Given this list of marker genes ALOX5, RALGPS2, TRMT112, TACSTD2, PLOD1, PDSS2, PTP4A1, F2RL1, B3GNTL1, RNF141, RFC2, CXCR1, ADGRE2, TBL1X, POLB, SORL1, RAB11FIP1, G6PD, TACC3, RPS6KA5, APOBEC3A, NDST1, NUDT15, RAB3A, PECAM1, OSBPL9, GRAMD1C, KAT6A, ZNF407, TNRC6B, BMX, STK17A, FYB1, MERTK, HAL, NDUFB6, USP6NL, SLC25A37, SIPA1, TGM5, WRAP73, PIGF (phosphatidylinositol glycan anchor biosynthesis class F), RBPJ, CORO1A, ABCC5, TRANK1, TCAP, FRAT2, RXRA, IFRD1, MT4, MNDA, RAF1, HMGCR, ELOVL5, ARHGDIB, SMCHD1, CEACAM21, BIN2, ATXN7, P2RY13, GAPDH, MPPE1, INKA2, TUBA4A, USP3, FOS, CAMK2G, CDA, AADAC, TNFRSF10B, DNAJC28, INTS8, ARID3B, EXOSC2, CEP295, TKT, SDHD, NRAP, TWF2, DHRS7, GUCA2B, CALML4, IRGC, SUMO1, FOXO3, ZNF443, GLIPR1, ZPR1P1, ING1, RALBP1, GPR15, LBR, TRAPPC12, DNAAF2, KLHL2, GALNT3, ZBTB44, EPCIP, PANK2, TNFRSF10C, ZNF500, CXCR2, KATNB1, SOS2, PGAP2, ARHGAP19 (NCBI Gene Id 84986), THOP1, SELL, DAPK1, ZNF516, S100A4, AVIL, NFIC, PYGO1, UBR2, ABHD18, PHTF1, IFT25, UIMC1, CPQ, LMO4, DIRAS3, ADCY7, RUFY2, MEF2C, ZNF528, PPP1R7, ANKRA2, XYLT2, TUBA1A, KCTD2, PYCARD, CHST11 (carbohydrate sulfotransferase 11), PARP8, IRAG2, MUC6, S1PR4, FURIN (NCBI Gene Id 5123), RGS2, ABCF1, ZYX, SLC7A2, MYL3 (NCBI Gene Id 4634), TST, SLC22A4, COTL1, OMD, DAPK2, CBX1, CD302, CCPG1, LRRK1, SCAP, SHCBP1L, AKR1C3, OSTF1, BLTP1, ICAM3, NARF, RGS14, GRWD1, TASL, CEP63, CABP1, CPPED1, TRIM8, AMPD2, BMP2K (BMP2 inducible kinase), NAA40, TMX4, FAM53C (NCBI Gene Id 51307), MTX1, IL18, AGO4, LIPF, SGCG, ZFP36L2, RAB11A, VDR, TSC22D3 (NCBI Gene Id 64477), MIA3, GNA14, KCNN2, PLEC, CPEB3, KDM4B, AOAH, LDHA, MAP3K3, CDKAL1, HHEX (NCBI Gene Id 5556), TOPORS, DDAH2, SP140L, ETV6, TTLL7, IHH, here is a description of the gene set: Human Gene Set: GSE22611_NOD2_VS_CTRL_TRANSDUCED_HEK293T_CELL_DN NOD2 is an intracellular receptor for the bacterial cell wall component muramyl dipeptide (MDP) and variants of NOD2 are associated with chronic inflammatory diseases of barrier organs e.g. Crohn disease, asthma and atopic eczema. It is known that activation of NOD2 induces a variety of inflammatory and antibacterial factors. The exact transcriptomal signatures that define the cellular programs downstream of NOD2 activation and the influence of the Crohn-associated variant L1007fsinsC are yet to be defined. To describe the MDP-induced activation program, we analyzed the transcriptomal reactions of isogenic HEK293 cells expressing NOD2wt or NOD2L1007fsinsC to stimulation with MDP. Importantly, a clear loss-of-function could be observed in the cells carrying the Crohn-associated variant L1007fsinsC, while the NOD2wt cells showed differential regulation of growth factors, chemokines and several antagonists of NF-κB, e.g. TNFAIP3 (A20) and IER3. from publication Billmann-Born S, Till A, Arlt A, Lipinski S, Sina C, Latiano A, Annese V, Häsler R, Kerick M, Manke T, Seegert D, Hanidu A, Schäfer H, van Heel D, Li J, Schreiber S, Rosenstiel P (PMID 21335489) species: Homo sapiens Genes down-regulated in HEK293 cells: over-expressing wildtype NOD2 versus control.